The following is a description of a gene set: Genes down-regulated in blood vessel cells from wound site. Human Gene Set: ROY_WOUND_BLOOD_VESSEL_DN from publication Roy S, Patel D, Khanna S, Gordillo GM, Biswas S, Friedman A, Sen CK (PMID 17728400) species: Homo sapiens Chronic wounds represent a substantial public health problem. The development of tools that would enable sophisticated scrutiny of clinical wound tissue material is highly desirable. This work presents evidence enabling rapid specific identification and laser capture of blood vessels from human tissue in a manner which lends itself to successful high-density (U133A) microarray analysis. Such screening of transcriptome followed by real-time PCR and immunohistochemical verification of candidate genes and their corresponding products were performed by using 3 mm biopsies. Of the 18,400 transcripts and variants screened, a focused set of 53 up-regulated and 24 down-regulated genes were noted in wound-derived blood vessels compared with blood vessels from intact human skin. The mean abundance of periostin in wound-site blood vessels was 96-fold higher. Periostin is known to be induced in response to vascular injury and its expression is associated with smooth muscle cell differentiation in vitro and promotes cell migration. Forty-fold higher expression of heparan sulfate 6-O-endosulfatase1 (Sulf1) was noted in wound-site vessels. Sulf1 has been recently recognized to be anti-angiogenic. During embryonic vasculogenesis, CD24 expression is down-regulated in human embryonic stem cells. Wound-site vessels had lower CD24 expression. The findings of this work provide a unique opportunity to appreciate the striking contrast in the transcriptome composition in blood vessels collected from the intact skin and from the wound-edge tissue. Sets of genes with known vascular functions but never connected to wound healing were identified to be differentially expressed in wound-derived blood vessels paving the way for innovative clinically relevant hypotheses., and this is the list of marker genes: EPB41L4B, SOX9, SLC6A14, KRT14 (NCBI Gene Id 387571), KRT15, ATP1B1, SCGB2A2, S100P, CD24, CEACAM6, ERBB3, DSP, SFRP1, FBXO9 (F-box protein 9), PROM1, F5, C1orf116, KLF5, GABRP, RNF43, H2AC25, ATP8B1, ANXA8 (annexin A8)